The following is a description of a gene set: Mouse Gene Set: CUI_MONOCYTE_IL2_RESPONSE_UP species: Mus musculus Genes positively differentially expressed in cell type: Monocyte upon treatment with cytokine: IL-2 in mouse lymph nodes in vivo. Cytokines mediate cell-cell communication in the immune system and represent important therapeutic targets. A myriad of studies have highlighted their central role in immune function, yet we lack a global view of the cellular responses of each immune cell type to each cytokine. To address this gap, the authors created the Immune Dictionary, a compendium of single-cell transcriptomic profiles of more than 17 immune cell types in response to each of 86 cytokines (>1,400 cytokine-cell type combinations) in mouse lymph nodes in vivo. A cytokine-centric view of the dictionary revealed that most cytokines induce highly cell-type-specific responses. For example, the inflammatory cytokine interleukin-1β induces distinct gene programmes in almost every cell type. A cell-type-centric view of the dictionary identified more than 66 cytokine-driven cellular polarization states across immune cell types, including previously uncharacterized states such as an interleukin-18-induced polyfunctional natural killer cell state. from publication Cui A, Huang T, Li S, Ma A, Pérez JL, Sander C, Keskin DB, Wu CJ, Fraenkel E, Hacohen N (PMID 38057668), and this is the list of marker genes: Socs1, Cxcl10 (C-X-C motif chemokine ligand 10), Fn1 (fibronectin 1), Irgm1, Samhd1 (NCBI Gene Id 56045), Ifi47, Igtp, Gda, Irf1, Slfn2